The following is a description of a gene set: Human Gene Set: GOBP_NEGATIVE_REGULATION_OF_INTRINSIC_APOPTOTIC_SIGNALING_PATHWAY species: Homo sapiens Any process that stops, prevents or reduces the frequency, rate or extent of intrinsic apoptotic signaling pathway., and this is the list of marker genes: ING2, IL10, MMP9, PPIF, NOL3, MIR17, TAF9B, BAG5, CCAR2, MAGEA3, XBP1, LRRK2, MIR132 (microRNA 132), SELENOS, PDX1, BID, RACK1, CTNNB1, PTGS2, PIK3CB, DNAJA1, MIR29B1, TXNDC12, PARK7, HYOU1, NFE2L2, MIR19A, WFS1, MAPK8IP1, HSPB1, MAP2K1, PTPN1, WNT1, TMEM161A, PARL, HERPUD1 (NCBI Gene Id 9709), BCL2 (NCBI Gene Id 596), MAPK7, MUC1, ELL3, BDKRB2, ATF4, HDAC1, PYCR1, CREB3L1, CDKN2D, FBXO7, SNAI2, GRINA, PINK1, URI1, FZD1, RRN3, SFRP2, CD74, SIRT1, SRC, CD44 (CD44 molecule (IN blood group)), OPA1, CLU, IKBKG, TRIAP1, USP47, MIR195, INS, TAF9, TRAP1, SNAI1, IVNS1ABP, HELLS, MDM2, ENO1, ACKR3 (NCBI Gene Id 57007), ARHGEF2, ARMC10, ZNF385A, MIR21, BCL2L1, SYVN1, NME5 (NME/NM23 family member 5), SOD2, PPIA, ATAD5, MARCHF7, PRKN, HIF1A, CREB3, RTKN2, FIGNL1, NOC2L, NONO, HTRA2, GATA4, GPX1, FGF2, BCL2L12, AKT1, EPO, DDX3X, PLAUR, TPT1, MIR92A1, TRIM32, YBX3, RRM2B, DDIAS, KDM1A, FYN, MIF, MIR133A1, PTTG1IP, CXCL12, HSPA1A, TMBIM6